Given this list of marker genes UNK, PKNOX2, NT5E, TMEM25, KCNQ2, LRRC75A, ZNF367, ZNF521, GTPBP1 (NCBI Gene Id 9567), CAMK2G, TRAF3, SDC3, ACSM2B, RASD2, STAR, NAV1, CCAR2, ADGRL1, AGBL5, NUMA1, TRPM2, FHIP2A, PLXNA3, ZFP36, CARMIL1, PDE6D, PTPRN2, ELAC1, LZTR1, AK5, here is a description of the gene set: species: Homo sapiens from publication Chen Y, Wang X (PMID 31504780) Human Gene Set: MIR7160_3P Genes predicted to be targets of miRBase v22 microRNA hsa-miR-7160-3p in miRDB v6.0 with MirTarget v4 prediction scores > 80 (high confidence targets).